The following is a description of a gene set: The cellular and vascular changes occurring in the endometrium of the pregnant uterus just after the onset of blastocyst implantation. This process involves the proliferation and differentiation of the fibroblast-like endometrial stromal cells into large, polyploid decidual cells that eventually form the maternal component of the placenta. species: Homo sapiens Human Gene Set: GOBP_DECIDUALIZATION, and this is the list of marker genes: PARP1, STC1, TCF23 (NCBI Gene Id 150921), DCAF13, VDR, TPPP3, EPOR, SPP1, PTGS2, STC2, BSG, CITED2, LIF, PTGIS, JUNB, CYP27B1, PPARD, PTN, CTSB, PARP2, GHSR, ASH1L, DEDD, NDP, GHRL